Given this list of marker genes FGB, ICAM4, CD47, COL9A1, COL4A3, ITGA1, FBN1, ITGB8, FN1, COL3A1, ITGA4, JAM3, PECAM1 (platelet and endothelial cell adhesion molecule 1), COL5A3, COL4A5, ITGA3, VCAM1, COL6A3, FGA, COL9A2, FGG, ITGB6, COMP, ITGAV, ICAM1, COL8A1, COL6A5, COL6A6, COL13A1 (collagen type XIII alpha 1 chain), ITGB5, CDH1, COL10A1, COL16A1, ITGAE, CD44, MADCAM1, ITGA9, ITGB2, TNC, COL4A6, ITGAL, COL23A1 (NCBI Gene Id 91522), ITGA10, COL9A3, ITGB3, ITGAM, COL5A2, VWF, ITGA5 (NCBI Gene Id 3678), VTN, ITGA2B, F11R, ITGA11, COL18A1, COL8A2 (collagen type VIII alpha 2 chain), KDR, HSPG2, COL6A2, BSG, ICAM3, COL2A1, ITGA7, ICAM5, ITGB1, COL5A1, COL4A4, ITGAX, COL7A1, COL4A2, SPP1, ITGA6, ITGA8, THBS1, COL6A1, COL1A1, IBSP, LUM, ICAM2, JAM2, ITGA2, COL1A2, ITGB7, COL4A1, AGRN, ITGAD, here is a description of the gene set: part of: Extracellular matrix organization Reactome Pathway: Integrin cell surface interactions The extracellular matrix (ECM) is a network of macro-molecules that underlies all epithelia and endothelia and that surrounds all connective tissue cells. This matrix provides the mechanical strength and also influences the behavior and differentiation state of cells in contact with it. The ECM are diverse in composition, but they generally comprise a mixture of fibrillar proteins, polysaccharides synthesized, secreted and organized by neighboring cells. Collagens, fibronectin, and laminins are the principal components involved in cell matrix interactions; other components, such as vitronectin, thrombospondin, and osteopontin, although less abundant, are also important adhesive molecules.<br>Integrins are the receptors that mediate cell adhesion to ECM. Integrins consists of one alpha and one beta subunit forming a noncovalently bound heterodimer. 18 alpha and 8 beta subunits have been identified in humans that combine to form 24 different receptors. <br>The integrin dimers can be broadly divided into three families consisting of the beta1, beta2/beta7, and beta3/alphaV integrins. beta1 associates with 12 alpha-subunits and can be further divided into RGD-, collagen-, or laminin binding and the related alpha4/alpha9 integrins that recognise both matrix and vascular ligands. beta2/beta7 integrins are restricted to leukocytes and mediate cell-cell rather than cell-matrix interactions, although some recognize fibrinogen. The beta3/alphaV family members are all RGD receptors and comprise aIIbb3, an important receptor on platelets, and the remaining b-subunits, which all associate with alphaV. It is the collagen receptors and leukocyte-specific integrins that contain alpha A-domains. studied in species Homo sapiens